The following is a description of a gene set: studied in species Homo sapiens Human Gene Set: MIR522_3P from publication Chen Y, Wang X (PMID 31504780) Genes predicted to be targets of miRBase v22 microRNA hsa-miR-522-3p in miRDB v6.0 with MirTarget v4 prediction scores > 80 (high confidence targets)., and this is the list of marker genes: SMURF2, HORMAD1, KPNA4, DHFR2, ELAVL1, PTPN11, ZBTB20, CASKIN1, ENTPD4, KIF7, BEND4, FLRT3, CSTF2T, HNRNPLL, PLXDC2, ABHD3, ZC3H8, PRKAA1, STK4, CADM1, NFIB, CUL1, SPICE1, AMMECR1, RAP2A, KRTAP3-1, SPRY3, FBXO8, TBC1D9, COL5A2, ZNF594, PTPN4, RABEP1, MST1L, DPYSL2, SCAF11, MYEF2, ABCB5, ATXN1L (NCBI Gene Id 647512), ARHGAP29, RPS3, MBNL3, WDFY3, NSD2, NOXRED1, ARMC10, FAHD1 (fumarylacetoacetate hydrolase domain containing 1), MRPL47, FHIP2A, NEUROD1, KLHL31, ATXN7, OAS1, PPFIA2 (NCBI Gene Id 8499), VAPA, KLHL8, P2RY10 (NCBI Gene Id 27334), SHOC2, DNAJC25, YWHAQ, LMO7, FST, PDIA5, RAPGEF6, SLC4A7, DHFR, MZT1 (NCBI Gene Id 440145), SYNJ1, RFX7, DIMT1, ZBTB6, RAC1, TMEM266, RHD, SIAH1, PERP, ADA2, PPM1E, TCP11L2, CCSER2, MEF2C, EIF2A, EEF1AKMT2, PLIN4, MAFB, SEMA5A, ETV1, ZC3H7A, HS3ST3A1, UBE2Q2, GARRE1, FMR1, NRG3, NPAT, RSL24D1, LZIC, UBR3, MPO, CSNK1A1, ABCD4, SLCO4C1, GIN1, RBM47, METTL13, TAOK3, SNX1, SLC12A6, CLVS1, AMMECR1L, NHLRC1, MID1, C15orf40, SMAD2, RASGRP3, RAVER2, GOLGA1, TOR1AIP1, MCMDC2, PIK3CA, MTMR3, FEM1C, PHIP, LSM5, FANCD2, RCAN3, AKAP6, SNAP25, RAB14, NFAT5, STAG1, CCDC186, GAB2, PIP4P2, ZMAT3, NEXMIF, INO80D, PARP15, GEM, CHIC1, ARPC5, BCL2, ATP1B1, TLR8, DLG2, RAB38, SC5D, LARP1B, PRKG1, TAF1C, ZDHHC6, CDK6, TRPM7, RB1CC1, WWTR1, DIP2A, ATF7IP, TNFSF4, DEPDC4, TM2D1, GDAP2, USP8, TNRC6B, DOCK7, NDUFA5, SLC45A2, FUT9, GPRASP3, TXNDC9, MTCL3, TMTC4, LPAR1, TP63, ADGRF2P, ARHGAP5, DCHS2, WT1, DLG1, CNOT6L, WDTC1, CBLL1, TUBGCP5